Given this list of marker genes HLA-DRB5, CTSL, HLA-DMB, HLA-DRA, CD74, DNM2 (NCBI Gene Id 338330), FCER1G, TRAF6, B2M, HLA-DOB, CTSF, HLA-DRB1, HLA-DQB1, FCGR2B, HLA-DQA2, HLA-DOA, UNC93B1, PIKFYVE, CTSD, CTSV, HLA-DPB1, HLA-DQA1, LGMN, HLA-DRB3, CTSS, HLA-DPA1, CTSE, HLA-DQB2, HLA-DRB4, HLA-DMA, IFI30, here is a description of the gene set: Human Gene Set: GOBP_ANTIGEN_PROCESSING_AND_PRESENTATION_OF_EXOGENOUS_PEPTIDE_ANTIGEN_VIA_MHC_CLASS_II The process in which an antigen-presenting cell expresses a peptide antigen of exogenous origin on its cell surface in association with an MHC class II protein complex. The peptide antigen is typically, but not always, processed from a whole protein. species: Homo sapiens